The following is a description of a gene set: Human Gene Set: GOZGIT_ESR1_TARGETS_DN Genes down-regulated in TMX2-28 cells (breast cancer) which do not express ESR1) compared to the parental MCF7 cells which do. We have used a novel variant of the human oestrogen receptor (ER)-positive MCF-7 cell line, TMX2-28, as a model to study breast cancer. TMX2-28 cells show no detectable levels of mRNA or protein expression for the ER and express basal cytokeratins (CKs) 5, 14, and 17. cDNA microarray comparison between TMX2-28 and its parent cell line, MCF-7, identified 1402 differentially expressed transcripts, one of which was, phospholipase D1 (PLD1). Using real-time RT-PCR, we confirmed that PLD1 mRNA levels are 10-fold higher in TMX2-28 cells than in MCF-7 cells. We next examined PLD1 expression in human breast carcinomas. Phospholipase D1 mRNA levels were higher in breast tumours that expressed high-mRNA levels of basal CKs 5 and/or 17, but PLD1 mRNA levels were not significantly higher in ER-negative tumours. Phospholipase D1 protein was overexpressed in 10 of 42 (24%) breast tumours examined by IHC. Phospholipase D1 was overexpressed in 6 of 31 ER-positive tumours and 4 of 11 ER-negative tumours. Phospholipase D1 was overexpressed in three of the four tumours that showed high CK5/17 expression. Five PLD1-positive tumours were negative for phospho-Akt expression, but positive for phospho-mammalian target of rapamycin (mTOR) expression. The other five PLD1-positive breast tumours showed positive expression for phospho-Akt; however, only two of these cases were positive for phospho-mTOR. In this study, we report that PLD1 and phospho-mTOR are coexpressed in a subset of phospho-Akt-negative breast carcinomas. species: Homo sapiens from publication Gozgit JM, Pentecost BT, Marconi SA, Ricketts-Loriaux RS, Otis CN, Arcaro KF (PMID 17726467), and this is the list of marker genes: LMCD1, DR1, FRAS1, SP100, NMD3, TCEAL1, ENSG00000284634, PLEKHA7, FUT8, BAMBI, PXDN, LARGE1, ATP1B1, AOX1, RERG, PABIR1, FLCN, RUBCNL, OTULINL, ATP2A3, MLLT3, SDR16C5, DSCAM-AS1, MACROD2, MACF1, ZNF625, TMEM219, NELL2, MARCKS, RNASE1, TGIF2, DUSP8, RFTN1, THBD, CALCR, PYCARD, CEMIP, SHROOM3, NPNT, XAF1, DPF3, CYTOR, LTBP2, SCCPDH, HOXC6, PCDHB10, AHI1, CNTN1, HOXC13, SPTSSB, ENSG00000234387, CMBL, SLC25A30, PTGR1, EDN1, ZNF641, SP140L, PIAS3, SELL, CPT1A, MSANTD2-AS1 (NCBI Gene Id 100508016), TMEM140, ZNF506, SRSF4, NINJ1 (NCBI Gene Id 4814), PLCXD2, VOPP1, AGR2, FOXA1, H3C10, AJUBA, TSC22D3, ICA1L, KRTAP3-2, FBXO32, PDK3, TRIM38, CLDN3, CEACAM6, LGALSL, MID2, GDF15, H4C8, GASK1B, SGK3, ABHD4, PTPRG-AS1, AKR1C1, PSTPIP2, TWIST1, DNAJC12, MMP16, DTNA, ELL3 (NCBI Gene Id 80237), HHEX, SLC27A2, SH3BGRL, LPAR6, SLITRK6, MSMB, ARL15, KITLG, SNX16, AP5S1, SLC46A3, LIN7A, MATN3, COL18A1, SLC16A7, SYNPO2, STC1, LINC02848, LEPR, PKIB, IGFBP5, SLC24A3, GRIN2A, TDRD1, DOCK8, DNAJA4, FGF14-AS2, NAB1, PARP10, HAGLR (NCBI Gene Id 401022), STMN3, DSCR8, CPNE4, EPB41L5, IDS, HDGFL3, RPS6KA2, MASP1, BLVRA, NREP, CPEB2, CLU, HIPK2, PSG4, CRACR2A, GSTT1, SCPEP1, IRS1, EPHA3, ABCC1, TNFAIP3, MVP, ERN1, COBLL1, SLC12A6, SIDT1, EMC10, GPC4, CEACAM1, CSNK1D, SHROOM2 (NCBI Gene Id 357), TANC2, CXCL16, HES4, GSTA1, RIPPLY3 (NCBI Gene Id 53820), THSD4, NECAB1, HMGCLL1, VAT1 (NCBI Gene Id 10493), SPRED2, CTSF, EPS15L1, OAS2, PLEKHA5, PCP4, FAXDC2, IGFBP6, ST8SIA4, DPYD, RNF43, SMIM5, MAOA, UTRN, ZC2HC1A, CTSS, DEPTOR, C6orf141, SNAPC3, NCAM2, ARMT1, MAN1A1, SLC39A13, ENPP1, DACH1, GPR137B, ST3GAL1, PRDM11, ENSG00000265246, GNRHR, PGR, SCUBE2, ZNF583 (zinc finger protein 583), SLC16A6, MPZL1, TFPI, PPP1R3C, EGLN3, EFNB2, RBPMS, GNA14, GPNMB, PCGF5, RND3, GBP2, GULP1, ACSL3, SNAP29, TIMP2, CREB3L2, C1orf53, SLC19A2, IRF9, AKAP5, GRHL2-DT, SYT1, MBNL3, KANK1, SERPINA1, WIPI1 (WD repeat domain, phosphoinositide interacting 1), GLRA3, TSPAN13, LINC00205, AHR, RHOQ, LINC00052, MAGED1, SLC1A1, CLNK, FGF13, GATA3-AS1, LINC01213, SIPA1L2, HOXA10, TRIQK (NCBI Gene Id 647518), PPM1L, IFI27, TMPRSS4, RAB29, FUT8-AS1 (FUT8 antisense RNA 1), SGCG, C8orf88, AHCYL2, PLCB1, HK1, DSPP, CKAP4, ZNF223 (zinc finger protein 223), HOXB-AS1, LINC00992, C11orf52, NAT1, ARMCX3, SALL3, TMTC1, MUC20, BCAS1, CD44-AS1, H2BC8, IFI44L, LCN2, KLF7, FRMD6 (FERM domain containing 6), UCP3, PRSS23, CDKN2B, LYPD1, ADGRG1, RBMS2, PSD3, SAMD9, RAI1, SRRM2, LDB3, SLC12A2, ZNF285, SEMA3C, UBE2QL1, SH3BGRL2, TBC1D2, GRIK3 (NCBI Gene Id 2899), TOM1L2, TEAD2, ALOX15, SPATA31A7, RASD1, LILRB3, ARL4A, ENSG00000278932, IGF2BP2-AS1, TFF3, GPATCH2, SYTL5, EEF1A2, GAD1, SRGAP1, LMNA, PDGFRL, H2BC21, WLS, UGDH, AFF3, USP18, MIR3648-1 (microRNA 3648-1), NUP210L, PPM1E, PSG6, CYP19A1, ZSWIM6, UGCG, RGS22, CSTA, SAT2, ACOT2 (acyl-CoA thioesterase 2), SDK1, BMP5, TNFRSF11B, C2CD4A, CNOT4, OSR2, AGR3, PLXNA3, ATP2B1-AS1, MED14, VDR (vitamin D receptor), MIR4500HG, MEG3, AMER2, MYO6, RPRM, TPK1 (NCBI Gene Id 27010), PATJ, FOXP1, CD44, HLA-DPA1, FLRT3, KDR, KLF3-AS1 (KLF3 antisense RNA 1), ANKRD50, SGSM2, C6orf118, SDR42E1, HS3ST5, AKR1C3, KRT13, NNT, TFF1, C9orf152, CAP2, NUDT14, RCBTB1, SPART, CP, PSMB8-AS1, PSMB8, ATP9A, KCNJ3, TRPS1, ANK3, SP110, PTPRG, ADGRF4, PLEKHB1, RAB27B (RAB27B, member RAS oncogene family), PGAP6, TGFBI, ULK1, IFIT1 (interferon induced protein with tetratricopeptide repeats 1), SLC7A2, ATP11B, AR, ADAMTS19, CACNG4, SLC37A1, NRP1, SLC1A2, TACSTD2, PLLP, IGFBP4, CFAP20DC, SELENBP1, CASK, ARFGEF3, TGFA, FTH1, NBEA (NCBI Gene Id 55091), ENSG00000288109, HLMR1 (hepatic lncRNA metabolic regulator 1), TMEM64, CCDC83, TP53TG1, CTNND2, ATRNL1, RLN2, SLC39A8, PSG3, SEC14L1, CYP2C8, PPM1K, BIRC3, FUT9, EPB41L1, PSG9, SCNN1A, JAG1, PLK2, SLC39A6, KYNU, LNCAROD, ARMCX2, PTTG1IP, C3orf70, DHRS3, NR5A2, FRK, NFKBIZ, SLC27A6, EPHX1, RBBP6, DUSP10, H2AC8, SLC25A29, MLPH, VLDLR, SAT1, MIR22HG, CUEDC1, LSM14B, SIGLEC15, MPDZ (NCBI Gene Id 8777), MS4A15, PGM3, RAB30, CREM, OR7E14P, STRBP, CACNB4, PRICKLE2, NEK6 (NCBI Gene Id 58167), BAG3, LINC01087, ASAP1, GPR37, COA1, MBOAT1 (membrane bound O-acyltransferase domain containing 1), NEBL, GPC1-AS1, LINC02482, SGMS1, SCGB1A1, NR2F2, CCL28, TGFB2, HMCN1, SYTL2, MMP25, RASGRP1, AREG, HOXC10, CCPG1, CMAHP, MUCL1, VMP1, ZNF229, APOL1, GFRA1 (NCBI Gene Id 2674), MAPRE3, PROCR, ST6GALNAC5, LCA5, PRLR, TMEM150C, CELSR2, NECTIN2, ZNF226, CDCA7L, PCDHB16, VAV3, CYP1A1, POF1B, PGPEP1, TRIM2, TRIB2, RASSF5, DSP-AS1, TTC9, IRF7, DHDDS-AS1, IFIT2, SMIM22, UCP2, NF2, RUNX2, EFEMP1, TMEM106C, EGR3, CXCR4, MAF, ELP2, TEKT4P2, SERPINA5, SLC16A14, ITGA6, DNM3, SAMD9L, CHROMR (cholesterol induced regulator of metabolism RNA), GRIPAP1, MYO5A, TNFSF10, SHANK2, GALNT4, SERPINA3, GALNT18, BMPR1B, IRX5, SPTBN2, TIGD6, CHD8, SPAG4, MPPED2, EVL, YTHDC1, STC2, HLA-DRB1, GATA6, TTC39A, NPAS3, TSPAN1, KCTD15, CRABP2, TC2N, IGHE, COL4A5, FBP1, TRANK1, CDKL5, RET, MED15P9, PLAAT3, RABEP1, TMEM45B, ABAT, NSL1, GPER1, PLEKHS1, RAB40B, CHST15, TALAM1, CRISP3, TRIM49, GREB1, XIST, SLC6A14, TSPAN15, SLC9A7, REL, SULF1, HSH2D, SOX2, ZPLD1, RNF144B (NCBI Gene Id 255488), TCF4, IFIT3, DENND1B, BATF2, HLA-DQB1, UNC5C-AS1, ZDHHC15, TLE1, ARID5B, SFXN2, IGF1R, FAM169A, STAP2, DCLK1, PKIA, LOXL1-AS1, PLCH1, VIL1, ITGB8, ACKR3, PCSK6, HS6ST2, ENTREP1, ABLIM1, OLFM1, ZG16B, ENSG00000237773, CCDC170, MICB (NCBI Gene Id 91956), INPP4B, PCDHB7, GATA3, APOD, ZGPAT, APBB2, GPX2, LRCH1, PTK2, ELF5, UAP1L1, AK4, MYO1B, NRCAM, TBC1D9, GRHL2, IFITM10, PRKAR1A, MT2A, TUBA1A (tubulin alpha 1a), PTPRK, ATP8B2, RBFOX2, MITF, MTSS1, ARG2, SLC12A2-DT, NEAT1, MAP4K3-DT, CA12, H3C4, LGALS8, CBLB, CD109, DCDC2, SMIM14, FGFR2, B3GALNT1, FAR2, SGK1, SPATA13, VEZF1, NUCB2, TENT5A, NPC2, C4A, LRATD1, STON2, ISG20, PLPP1, KCNK6, PRR15L, PCDHB14, CHMP4A, LDOC1, GPR137C, IFI6, HERC6, ARPIN, SCRN1, PTPN13, TBX2, PRRT3, KDELR3, CRYBG1, ARRDC3 (arrestin domain containing 3), GABBR1, PRSS35 (serine protease 35), CAPN9, RUNDC3B, SOX3, CXCL12, SUSD4, HID1, FIGN, TIMP1, LPIN2, LURAP1L, JUN, KIAA0513, TGM2, LRRCC1, ANKRD26P3, GLMP, PIK3R3, MB21D2, YPEL2, PMEPA1, AOPEP, SYTL1, RGCC, GABARAPL1, CPE, ALCAM, ERBB4, DIRAS2, TMSB4X, PCDH7, GUCY1B1, TFPT, IFT122, S100A6, HOXB3, FAM114A1, PCDH10, NUAK1, SESN3, FARP1, ABCA12, ZNRF1, EPHA7, DNAJC15, PGM2L1, EPHA4, PFN2, FAT1, ABCA5, CAV2, STAT1, PRTFDC1, DSCAM, EEIG1, MARVELD3, H4C14, TCEAL3, SCD5, LINC02984, ZHX2, INPP5F, COL3A1, LINC02889, DIP2A, CFB, HTR7, ADCY9, BCL6, PCGEM1, SMURF2, CDK6, PGBD5, PRKCA, FAM241A, PIERCE2, SDK2, MAST4, CEACAM5, SLC2A10, CERS6 (ceramide synthase 6), ENAH (NCBI Gene Id 55740), CCDC169, NME7, MAP2, GSN, SLC6A8, ATP2C2, TRIM37, HDAC9, CYP1B1, ZNF483, PRSS8, CCL5, CAB39L, BATF, FAM162B, LINC00824, MX1, DEGS2, RARA, PDZK1, DYNLT3 (dynein light chain Tctex-type 3), RHOBTB3, SEC24D, ELAPOR1, KLF9, LOXL1, PDLIM5, ABHD2, ANKRD35, VEGFC, BEX4 (NCBI Gene Id 56271), NUDT16, PAPSS2, FNIP2, CTHRC1, ESR1, ASB9, PDZRN3, CD99, SOX9, MCOLN3, DGKD, TMTC2, SUPT4H1 (SPT4 homolog, DSIF elongation factor subunit), SECTM1, THBS1, ADCY1, DKK1, BICD1